The following is a description of a gene set: A protein complex which is capable of catalytic activity. Human Gene Set: GOCC_CATALYTIC_COMPLEX species: Homo sapiens, and this is the list of marker genes: ZNHIT1, POP4, SUCLG2, COX8A, POLR1H, RAMAC, SRRM1, BRPF3 (bromodomain and PHD finger containing 3), PHF21A, NDUFC2, CDK1, TCEA1, IER5, SMURF2, PPP2R3B, KLHL30, PPP4C (NCBI Gene Id 5531), KANSL1L, POLR3A, SPSB1, FARSB, PPP1R3C (NCBI Gene Id 5507), PSMD11, MCCC1, PTPA, IRS1, UGT3A2, ERCC6, TRMT61A, PPP2R5C, PSMB1, DUOX2, BECN1, CCNB1, HSPB1, KLHL21, IGF1R, MT-ND5, FBXO39, ACACB, DLST, FBXO17, SETD1B, INO80, LDHAL6B, WDTC1, MTARC1, UXS1, SUPT3H, HNRNPU, SPSB3, MT-CO2, MARCHF6, ACTL6A, SETD1A, KRTCAP2, ATP6V0E2, THBD, SEL1L, KANSL2, COX7C, IMMP2L, HDAC1, DCUN1D5, CCDC103, RANBP10, GNG4, NCF1C, PPP1R3G, KGD4, EXT1, RBM15B, SMARCA2, PRAMEF20 (NCBI Gene Id 645425), SIAH1, TAF2, MT-CYB, RSF1, ELOC, DNAH17, POLR2M, BABAM2, HNRNPAB, CAMK1G, KLHL23, BCL7B, RAD51 (NCBI Gene Id 5888), PDK1, RAD23A, ATP6V0C, FBXO25, MTA3, GSK3B, MKLN1, ELOVL6 (ELOVL fatty acid elongase 6), YPEL5, ITPR1, CUL5, RNF144B, MAD2L2, BECN2, KEAP1, PPP2R5A, PPP4R3B, ANAPC4, NDUFA4L2, RALY, ATP6V1C1, DYDC1, SPTSSA, IFIT5, DNAL1 (NCBI Gene Id 83544), GMPR2, PFKFB1, PRPF8, PCMTD1, KLHL22, FBXL6, EZH1, PSMF1, NDUFA2, PIGC, CDK9, WRAP53, PIGT, ALYREF, RBM47, STING1, DYNLL2 (NCBI Gene Id 140735), CUL4A, TBC1D5, ZBTB7A, TAF11L9, HNRNPA3, BRD8, DYNLT5, TFPT, GNAI3, DNTTIP1, ZSWIM6, DNAH2, MED31, ZZZ3, FBXO11, IKBKB, SYF2, ANP32E, LAGE3, AMT, DCAF8L1, LDHC, HNRNPA2B1, HRAS, EXOSC9, FANCI, UQCRQ, UBQLN1, MIDEAS, DYNLL1, STK11, ZSWIM8, CRADD, PSMB7, PPP2CB, PPP2R5B, FBXL2, SUCLG1, RBM8A, DHX8, ERCC8, ZYG11B, PDCD6, PRKCSH, DEPDC5, TSN, SF3B3, PPIL3, SOCS2, KBTBD2, CCNA1, MSL3, TFIP11, EME1, UBE2E1, GNG7, PRAMEF1, DDX21, PDP1, ULK1, GUCY1A2, CDK11A, GMPPA, ACTG1, ATP5F1D, CDK5R1, AQR, NDUFV2, METTL1, POP1, KLHL6, PRAMEF26, GTF2H5, GNB3, BRPF1 (NCBI Gene Id 7862), GNAZ, CTR9, DCAF12L1, CDC26, DCAF8, DBF4, HDAC6, SMARCC2, ATP6V1B1, NDUFB11, PRPS1L1, PARD3, BCAS2, NDUFA13, PPIL2, SNRPG, DGCR8, GATAD2B, NUS1, CCNK, METTL4, DNAH11, CDK6, ANAPC15, FBXW4, FBXO2, PRKAG1, HDAC4, DNAJB2, TAF11L6, EXOSC8, SPG7, CAPNS2, HCFC2, TBK1, PRDM4, DCAF1, ELP1, PAN3, PNPT1, NDUFA1, PIGY, RBBP7, INO80D, ACVR1, PIGA, SUZ12, DCAF15, DECR1, AXIN1, KMT2C, DLD, APPBP2, ATP5F1EP2 (NCBI Gene Id 432369), DCAF11, SNRPB, TAF11L10, PRAMEF11, POLR2J2, DNMT3L, GNAI1, KLHL40, PPP4R2, PPP1R3B, JMJD1C, MIB2, STUB1, CYC1, PYCARD, FBXL16, EED, PLAU, CCNT2, ASCC1, P3H3, MCRS1, AGO4, TAF11, PIGH, MED7, POLA2, QPRT, STT3B, GNA11, DCAF10, KBTBD12 (NCBI Gene Id 166348), UTY, KLHL10, TAF13, MED8, C2orf49, DISC1, ABAT, GNL3L, ACTR6, STRADB (NCBI Gene Id 66009), SAP30, DCAF4, UQCRFS1P1, CCNJ, PARD6A (par-6 family cell polarity regulator alpha), DYNC1I2, PRKDC, EXOSC4, TADA3, TOP3A, GNG5, AMN1, TSEN54, NOX4, TRAF2, RMI2, LSM2 (NCBI Gene Id 57819), DNAH9, RAC1, PPP2R2B, GTF2H2C, KMT2B, LYRM4, RNF217, MRGBP, KANSL1, VCP (valosin containing protein), DKC1, ERCC2, CCNY, GNG13, NAA11, ECPAS, ATP5MG, POLR1A, ZYG11A, SPAAR, MT-ATP8, PPIL1, PRKAG2, MED21, GNG8, RPP25L, PFKL, LIG3, CDK12, RAC2 (Rac family small GTPase 2), WDR5B (WD repeat domain 5B), PSMD13, CUL9, NAA25, PRIM2, ATP6V1B2, PPP4R4, ARID1A, UQCRHL, RABGGTB, PRAMEF12, ATP5F1B, COQ5, UBE2B, ATG16L2, PDHX, SDHC, PSMD2, PSMD6, NSMCE2, DIS3, APOBEC3F, ATP6V0A1, DAPK1, RFC1, PPP2R3A, ATP5PO, MYBBP1A, ASB4, KLHL28, UBE2L3, APC, ATP6V1H, KARS1, ASB1, METTL14, TAF10, PPIE, DCAF5, TAF3, SETD5, SNRPF, TMEM258, DPM3, NDUFA12, CALM3, GTF2F1 (NCBI Gene Id 2962), DCAF8L2, NCF4, TAF12, DDOST, NDUFC1, TRIM37, HEXA, ACTR5, UBE2J1, CDK8, KLHL3, NCF1, DCAF12L2, ATAD5, AMFR, NEU2, CYB5R3, CTU1, SDHA, BICRAL, ATP5MF, CHD3, POLR3C, DNAH14, VPS72, BRAP, NRIP1, NDUFB1, RRAGC, GNA12, NCF2, COQ4, CCNF, NDUFB4, ZNF217, A1CF, MED13, CCNC, TAF7L, RPP14, POLR2J (NCBI Gene Id 5439), POTEJ, MED30 (NCBI Gene Id 90390), PHKG2, MT-ND4, CCNP, EEF1E1, FBXO31, NAA38, CYB5B, TREX1, TAF11L7, POLR3E, KLHL42, PRKACA, CDC5L, PSME2, KLHL7, IDH3B, CSNK2A1, GAN, ING1, ATP6V0D2, DYNLRB1, GNG5B, MT-ND4L, GNG2, PRAMEF27, FBXL4, PIK3CB, OSTC, FBXO42, BUD31, PIK3R4, ATG12, GTF2E2, SRRM2, DNAH12, ASB2, COQ3 (NCBI Gene Id 96592), LUZP1, SMG5, TRMT11, GTF2H3 (general transcription factor IIH subunit 3), PCGF6, DYNC1H1, TANK, DPF2, SDHD, SAP18, FBXO3, FBXL13, RRM1, ATP5MK, PRKX, HDAC8, CBLL1, GTF2B, CHM, KLHL15, P4HB, TMEM199, RRAGA, CWC22, ATXN7, ENO2, DNAH8, RIOK1, AIMP1, PDPR, CCNI, DHTKD1, AGO1, KDM3B, GCSH, NOXO1, PRAMEF4, PCGF2, GATB (NCBI Gene Id 5188), ATG3, SAMD7, SNX4, PSEN1, FEM1B, TERC, DTL, C1D, TBPL1, JADE1, PSMD3, PSMC4, APOBEC1, KLHL12, REV3L, MLEC (NCBI Gene Id 9761), PARD6G, PHKG1, CASC3, DYNLT4, SMG7, RANBP9, ABHD11, PHF12, PSMD4, TRAF7 (TNF receptor associated factor 7), ODAD1, FEM1A, MBD3, MTCO2P12, SNW1, KHSRP, POLR2L, SUDS3, ATP5PB, RBCK1, PSMD14, WDR5, MAVS, EP400, POLR3G, YEATS2, PPP2R1A, MORF4L1, CAT, PSMD9, POLR3D, XRCC6, FBXL15, DYNC1LI2, MMS19, DIS3L, MECOM, SAP130, GANAB, ING2, HCFC1, MAX, GNAI2, PDSS2, SAE1, DCAF12, EXOSC1, SS18, CHD8, CUL4B, COLEC10, RBM15, NDUFS4, TET1, POTEE (POTE ankyrin domain family member E), KLHDC10, C15orf48, GTF2E1, POMT1, RNF11, ARID4A, SOCS7, GSK3A, MYZAP, IARS1, PAAF1, PSMB2, TMEM183A, DCTN4, TAF7, POLR2F, DPH2, ATG101, PRAMEF33, FBXO9, UBE2V2, PRAMEF13, BICRA, KLHL41, POLR2A, FARSA, PRPF31, SEM1, SMARCD2, HERPUD1, KAT6A, GNB4, DCAF4L2, NDUFB2, ZFAND2B, JARID2, RBBP5, CDC27, KLHL17, CHD5, ING3, EXOSC3, RNF19B, CAPN1, ORMDL2, GNPTG, RPAP1, CAPN2 (calpain 2), RNASEH2B, PRKACG, PPP1R15B, ZFP36, FBXO44, PCGF5, NAA15, CDK14, PRAMEF19, KLHL5, PSMB8, CCNO (NCBI Gene Id 9998), PAXIP1, POLR3B, PPP2R2C, DPM1, PIGK, UBE2J2, KCTD2, ORMDL1, PRMT5 (protein arginine methyltransferase 5), PSEN2, HADHB, ATP6V0E1, ATG14, PHC1, ILVBL, ATG13, PRKY, COX6B1, U2AF1, PRAMEF2, CECR2, DNAI4 (dynein axonemal intermediate chain 4), SPCS3, HSD17B10, ACTL6B (NCBI Gene Id 51412), GPIHBP1, MCCC2, LSM3, TRMT112, SPTLC3, RMI1, INSR, PPP3R2, SUPT20HL2, CCNG2, TAF11L12, FANCD2 (NCBI Gene Id 2177), UQCRB, SPSB2, PFKP, EXOSC5, CDK19, RBX1, EIF4A3, COX5B, DNAH10, ORMDL3, RRAGB, MTREX (NCBI Gene Id 23517), FBXO32, NOXA1, ISCU, CYBB, POLR3H, HTRA2, ANAPC5, ATP6V1F, NAA16, FBXW5, ATP23, COX5A (cytochrome c oxidase subunit 5A), ERH, DAD1, HEXB, CDK13, HR, PSMD1, NDUFC2-KCTD14 (NCBI Gene Id 100532726), P3H4 (prolyl 3-hydroxylase family member 4 (inactive)), CHRAC1, TAF5, ASCC2, WDR38, DCAF4L1, KLHL35, SF3A1, LDHA, PRAME, TSNAX, SEC11A, PPP2R5E, PRKAR1A, PNN, UBE2A, SGF29, RNF168, ANKIB1, CXXC1, KDM6B, SPOPL, CDKN2D, SNRPD2, UVRAG, RNF14, PSG9, POLR2D, SMG6, RNASEK, NOX1, SIN3B, PPP1R3D, PPP1CA, GCLM, NDUFB9, MAPKAP1, AKAP5, FBXO4, AFG3L2 (NCBI Gene Id 573970), POLR1D, PPP3CA, DHX9, CCIN, BCL7C, TAF11L2, PPP3CC, PCCB, COX6A1, RPP30, QTRT2, PAFAH1B1, KLHL9, SF3A2, MT-ND6, CFLAR, PRKAG3, LSM11, GUCY1A1, NCOA6, GRHPR, WDFY3, PRKCZ, INO80B, ZDHHC9, NAA30, BCL11B, DNMT3A, DYNLT1, BRCA2, FBXO45, BCKDK, DNAH7, OST4, TADA2A, NAA35 (N-alpha-acetyltransferase 35, NatC auxiliary subunit), BPTF, GTF2H2, PIDD1, NDUFAB1, LARS1, SART1, PHF20 (PHD finger protein 20), SUMO4, KDM3A, RAC3, SUPV3L1, PHF10, HDAC10, DHX35, LMO7 (LIM domain 7), ERN1, CACYBP, ATP5MGL, SIN3A, CDC40, NAA20, PPP3CB, RAD23B, CDK10, HADHA, SPSB4, NSMCE3, DUOX1, NDUFB6, PHKA2 (phosphorylase kinase regulatory subunit alpha 2), CHD4, HDAC3, BRMS1, PRAMEF14, RPTOR, FBXW7, EXT2, RTCB, DDX23, JADE3, PRKAA2, RUVBL1, CRNKL1, PRAMEF6, NDUFV1, PRKAR2A, TAF11L11, ATM, TUSC3 (NCBI Gene Id 7991), ZNFX1 (NCBI Gene Id 57169), DDX41, RCOR2, FRG1, CREBBP, DROSHA, LIG4, KLHL38, SS18L1, MSL2, EZH2, CCNB3, CBX2, NSMCE1, PMPCB, POLR2G, FBXO27, KMT2E, ACTR8, GCLC, PSMA7, INO80E, MAT2A, TAF11L13, CBX7, PSMB11, CCNL1, THUMPD3, TAF9, DMAP1, DYNC1LI1, FBXL17, RNF8, DDX1, SMC6, DICER1, RBBP4, TICAM1, EPC2, CAMK2A, CFH, BAZ1B, GNG12, TOP2A, HNRNPA1L2, PPP2R2A, TSEN34, TAF5L, PSMD10, ELP5, DNAI3, CASP8, SUCLA2, PSMB10, PPP2CA, PHF1, ATP5F1C, ACTB, OGT, FBXO24, UBE2N, COX6C, RPP38, HNRNPC, NDUFB10, ACTL8, BCOR, USP22, NDUFA5, ATP5MC1, DCAF7, SESN2, ELP4, MAP3K7, ZER1, TRRAP, PRAMEF18, PSME3, TPR, FBXO10 (F-box protein 10), IVNS1ABP, UQCRH, DPF3, VIRMA, F13A1, DAW1, SINHCAF, PBRM1, SMC5, ATP6V1C2, OS9, NOP10, DBT, BLM, COX6B2, RIPK1, RUVBL2, CCNG1, NDUFA6, UQCR10, USP33, SPCS2, TEP1, ATP5MJ, PSMA8, NSMCE4A, GTF2A1L, CCNL2, GNG10 (NCBI Gene Id 2790), DYNC2I2, AIMP2, PLOD1, ANAPC7, CDK5 (NCBI Gene Id 1020), PSMA2, CTDNEP1, ANAPC1, ATP5F1E, DCUN1D3, FNTA, FAM8A1, RARS1, GOLGA7, SENP3, SEC11C, MSL1, FZR1, EXOSC6, NDUFAF2, POLD3, KBTBD3, MT-CO1 (NCBI Gene Id 4512), EPRS1, UQCRC2, NRBF2, GLDC, FBXO48, POLG, KANSL3, MAGOHB, PDHB, RTF1, ANAPC11, GATC, MED1, ATP6V0A4, POLA1, RPP40, PPWD1, TBL1Y, ATP6V1D, GTF2A2, FEM1C, DNAH5, PRAMEF25 (NCBI Gene Id 441873), HNRNPK, MPHOSPH6, FBXW11, TAF6L, POLD4, PPP2R5D, KCTD5 (NCBI Gene Id 91152), PIK3R2, NCOR1, RB1, PSMB4, ATG16L1, HDAC5, INSRR, APC2, ARIH1, RB1CC1, PPP1R3A (protein phosphatase 1 regulatory subunit 3A), BCKDHB, AKAP14, SF3B1, SIRT1, GPR37, CTNNB1, F3, WDR26, SEC11B, PRKAB2, SPTLC1 (serine palmitoyltransferase long chain base subunit 1), RPN1, KCTD17, ZSWIM4, N6AMT1, ATP6V1E1, THG1L, EID3, PPP1R15A, DCTN1, PRKCI, FNTB, USP14, RNF144A, CAND1, PSMC3, EXOSC10, PRKRA, TERT, NDUFS8, POLR3K, PSMC6, PTGES3, SUPT20H, NUDCD3, CAMK2B, PRKACB, ERCC3, SMARCC1, EME2, CCNQ, USP47, CDK11B, PSME4, BARD1 (NCBI Gene Id 580), UGT3A1, PPP1R3E, GMPPB (NCBI Gene Id 29925), CHML, F7, GNA14, KAT2B, NDUFV3, PSMB6, ATP6V0A2, CCND3, POLE2, DNALI1, INO80C, MBTD1, CCND1, PIGM, ASB11, COX7A2, GOLGA7B, ALG14, FCN3, NHP2 (NHP2 ribonucleoprotein), TOX4, C9orf72, ANAPC16, PCGF1, PAXX, FXN, CARHSP1, DBF4B, SUPT7L, CUL3, PFKM, PHF20L1, DNAI7, POLE, CRBN, CKS2, PSMD8, TNFAIP1, PHF19, AGL, KAT7, COQ7, ATP6V0B, KLHL2, NOX5 (NCBI Gene Id 79400), COMMD1, KAT5, UBQLN4, CDC16, PPP1R12A, MEN1, SMARCA4, TADA2B, RCOR1 (REST corepressor 1), ACVR2A, IKBKG, PEX2, ACD, HNRNPR, CCNB2, CWC27, DPH1, NKD1, POLG2, PARD6B, TAF11L14, TBL1XR1, PAN2 (NCBI Gene Id 9924), CCNE2, TXNL1, CBX5, MTOR, CHUK, EPC1, RTRAF, PRAMEF10, RNF19A, NAA50, PIK3R3, CDK3, PRPF6, NAA10, CBX6, COX6A2, FUT6, PLAUR, KLHL4, FBXO6, HPSE, LPL (lipoprotein lipase), CCDC115, SYVN1 (synoviolin 1), FBXL19, POP7, TSEN2, SNRPN, DHDDS, KLHDC1, PYDC1, DNAL4, MTA2, ACVR1B, BAZ2A, APH1A, PAFAH1B3, PLRG1, KLHL8 (kelch like family member 8), SOS1, NEDD4, ALG13, MT-CO3 (NCBI Gene Id 4514), PALB2, CASP9, GMPR, RRAGD, HDAC9, DMAC2, ATXN7L3, PHKB, SNRNP40, KLHL18, ATP5ME, SHOC2 (NCBI Gene Id 8036), MED11, OTULIN, GNA13, TADA1, PABPC1, TRPC4AP, PSMD5, DPF1, SNRPD1, NDUFA7, POLD1, DCLRE1C, SATB2, PSMA1, SPCS1, FBXL14, FBXO21, DNAH1, ELP6, SMCR8, BUB1B, TUFT1 (tuftelin 1), CDK4, UQCR11, WDR4, MAGOH, ATP5F1A, RICTOR (NCBI Gene Id 253260), POLR2E, PIGV, ARMC8, SMARCD3, DYDC2, PCGF3, QARS1, NDUFB8, NDUFA11, KDM1A (NCBI Gene Id 23028), BAZ1A, DDX5, NOX3, RNASEH2A, RABGGTA, COX7B2, PGGT1B, PAFAH1B2, ANAPC10 (NCBI Gene Id 25866), SNRNP200, SRSF1, MCM3 (minichromosome maintenance complex component 3), GPATCH1, CAPNS1, CDK2, POLE4, COX4I2, TRMT61B, BCS1L, NDUFA8, UBE3D, MOCS2, ARIH2, POTEKP, ZCCHC8, F13B, XRCC4, KLHDC2, DNAI1 (NCBI Gene Id 3393), PSMC2, NFS1, ADRM1, PEF1, PMPCA, RBM22, ANAPC2, BCL7A, CDKN1B, ATF2, DYNC2I1, CSNK2B, NDUFA4, ASB12, PSMD7, PIK3C3, CAMK2D, DPM2, BRCA1, MAT2B, HINT1, CYREN, PCNA (proliferating cell nuclear antigen), MTA1, NDUFA9, KLHL20, GTF2H2C_2, TRERF1, DNAH6, GNAT1, ATP6V1A, CDK2AP1, ARID2, HNRNPH1, ZFAND2A, UBE4B, MED12, MLST8, RNF31, LDHB, COQ9, TAF6, DR1, NCSTN, RAG1, DYRK2, AEBP2, GNAS, GATAD2A, PRKAB1, BOD1L1, BTRC, TBL1X, CASP2, NAT10, CUL2, DYNLRB2, GON7, GNAT3, POLR3F, IDH3G, ACVR1C, GID4 (NCBI Gene Id 79018), RNF2, UBE2S, GNB1, COX8C, NEK10 (NIMA related kinase 10), JADE2, HNRNPA1, SMARCB1, COX7A2P2 (NCBI Gene Id 345363), PAF1, TAF11L3, YY1AP1, POLR2C, NDUFS1, SLU7, GNG14, PRAMEF7, POLR2I, SAP30L (SAP30 like), CDK7 (NCBI Gene Id 116024), PSMD12, RING1, PHKA1, COP1, TBKBP1 (NCBI Gene Id 9755), DET1, UBE2I, CBX4, UBE2U, UBR2, PSMC1, NDUFS5, ZBTB8OS, IPP, NDUFS7, MAP3K5, GNB2, PIK3R1, XRCC5, FBXO46, TRMT6, FAP, RANBP2, PRICKLE1, CCNH, HNRNPF, COQ6, NDUFS6, DPY30, C17orf49, DYNC2LI1, MEGF8, BRD1, PPP2R1B, PSMB3, DYNC2H1, PPP2R2D, KBTBD7 (NCBI Gene Id 84078), CDKN1A (NCBI Gene Id 1026), ATP6V0D1, ANKRD9, DEK, PSMA5, HSD17B12, KLHL24, NCF1B, WTAP, MORF4L2, CCNE1, NCR1 (NCBI Gene Id 9437), LZTR1, GTF2F2, FAM98C, ELP2 (NCBI Gene Id 55250), TRIM40, CCNJL (NCBI Gene Id 79616), CCNT1, SLX4, IKBKE (NCBI Gene Id 9641), MT-ND3, TAF9B, PHC2, MED6, RERE, GNAT2, DCUN1D1, ATP6V1G2, MEAF6, WWP2, PRAMEF17, DNA2, FBXO38, TAF11L8, FBXL21P, SAMD11, UBE4A, COX10, DDA1, WDR77, STRADA, RPP21 (ribonuclease P/MRP subunit p21), DCAF6, CDC20B, TOPORS, GLMN, ZC3H13, HDAC7, TAF4B (NCBI Gene Id 6875), FADD, PIK3R6, TBP (NCBI Gene Id 6908), PPP1R3F, APH1B, CDC20, KLHL25, ATG5, MYO1C, SF3A3, NDUFB7, GNG3, KAT14, PPP3R1, PRP4K, CAMK2G, TRAF3, TAF1, PRAMEF22, ERC1, FBXL3, TAF11L4, PRIMPOL, FBH1, BCCIP, TPRKB, DCAF17, YJU2, RCHY1, FAM98A (NCBI Gene Id 25940), MGA, CSNK1A1, PRAMEF9, RMND5A (required for meiotic nuclear division 5 homolog A), HDAC11, CACTIN, RANGAP1, POLR1C, SNRPE, PHC3, RBM44, UBR3, PDHA1, PKLR, IMMP1L, ATP6AP2 (NCBI Gene Id 95880), ENY2, KLHL13, CALM2, TCIRG1, PRPS1, WDR83, GNAO1 (G protein subunit alpha o1), HNRNPA1L3, KCTD10, FBXL20, EXOSC7, MT-ATP6, SNRPA1, RNF40, PIGU (phosphatidylinositol glycan anchor biosynthesis class U), CDK16, PIK3R5, MED17, CTNNBIP1, BCL11A, ARID4B (AT-rich interaction domain 4B), ATP5MC3 (NCBI Gene Id 518), NDUFA3, PRIM1 (DNA primase subunit 1), POLR2B, HSD17B8, MNAT1, OGDHL, POLR1E, ATP6AP1, WWP1, MGRN1, UCHL5, MED27, UBE3C, CAB39L, ESS2, DDB2, ELP3, MAT1A, GTPBP3, KAT8, QTRT1, CDK5R2, PRAMEF5, PPP4R1, MRAS, NDUFA10, CNEP1R1, AZI2, RPN2, COX7B, DHX38, SMARCA1, ASCC3, EPOP, CCNA2, EP300, ASB9, PPP4R3A, DMAC2L, PRAMEF8, CKS1B, MTO1, ENO3, BMI1, PPP4R3C, CFDP1 (craniofacial development protein 1), WDR74, PRKN, NCCRP1, SMARCE1, UBAC1, TP53RK, RRM2B, P4HA1, WDR18, VPS4A, SUPT20HL1, POLRMT, DLAT, VAC14, FBXW8, GNA15, DNAH3, ENO4, XAB2, HNRNPM, DYNLT2, CCND2, TEX10, PDHA2, PIGS, AKAP4, UQCRFS1, CNPPD1, TAF1L, DACT1, FCN2, GTPBP1, MT-ND1, SPTSSB, PIAS4 (protein inhibitor of activated STAT 4), CLPP (caseinolytic mitochondrial matrix peptidase proteolytic subunit), ATP5PF, NDUFB3 (NADH:ubiquinone oxidoreductase subunit B3), DNAI2, PSMA6, POLD2, RNMT, POLR2J3, APOBEC3G, UBE2C, SCLY, DCUN1D2, SUGT1, KMT2A, RPPH1, LEO1, GNG11, CSNK2A3, ARID1B, MAEA, KLHDC3, RNF7, BOD1, DRC1, NME8, PAGR1, GNAL, CFAP70, MBIP, NDUFS2, KMT2D, LSM7, CCNI2, DYNC1I1, PPP1R9B, NHEJ1, CASP10, KAT2A, AXIN2, ATP5MC2, TENT2, MAGT1, PSMA4, PIGQ, COX4I1 (cytochrome c oxidase subunit 4I1), CDC23, CBX8, GTF2H1, FBXO8, PDSS1, PIK3CA, ASH2L, GID8, RFC4 (NCBI Gene Id 5984), TMED10, ENO1, SMARCA5, LAS1L, ATP5PD, ZNF335, TP53BP1, PRKAR2B, PELP1, SHARPIN, BRD9, CRCP, SKIC8, ANAPC13, DCUN1D4, METTL3, CBR4, PIK3CD, WDR93, SPOP, AMBRA1, OGDH, CDC73, GBA3, GNGT1, AGO3, DYNLT3, PRMT1, BRD7, CUL1, GNAQ, RCOR3, GNGT2 (NCBI Gene Id 2793), DNMT3B, UBR1, PRKAA1, EXOSC2, MT-ND2, MSL3B, KLHL1, FBXL12, SLF1, PDK2, KAT6B, FAM98B, RBMX, PRKAR1B, CWC15, MARS1, QRSL1, GTF2A1, RMND5B (NCBI Gene Id 64777), TGFBR1, NDUFS3, CLNS1A, RPP25, OSGEP, CSNK2A2, KBTBD6, POTEF, GNB5, PPP1R10, POP5, EFTUD2, GTF2H4, POLR1B, MBD2 (methyl-CpG binding domain protein 2), GAR1, TMEM183BP, DDB1, FBXL7, COX7A2L, SF3B5 (splicing factor 3b subunit 5), RNF20 (ring finger protein 20), AGO2, CWC25, SDHB, PRPF19, TAF4, SNRPB2, CLP1, PSMB9, KLHL11, PIGP, UBXN8, ATP6V1G3, VPS4B, ISY1, COLEC11, POLE3, FBXL5, PSMB5, KLHL29, BCKDHA, DCTN2, GPAA1, RRM2, PSME1, YEATS4, ENC1, ACTBL2, TARBP2, TGFBR2, SMARCD1, SF3B2, E2F6, DNHD1, ZSWIM5, TAF8, BRMS1L, HMGXB4, PRORP, DCAF16, THUMPD2, UBE3A (ubiquitin protein ligase E3A), DCAF13, ARMC5, CALM1, ELOB, POLR2K, BRCC3, CYBA, SNRPGP15, WDR82, SKP1, FBXO15, NFRKB, PCCA, ZFC3H1, PRAMEF15, ING4, TRIM21, POLR3GL, FBXO7, CUL7, CDK2AP2, NVL, SNRPD3, KDM6A, YY1, DYNLT2B, PPCDC, SLF2, MBL2, KCTD13, LRRC75A, NDUFB5, RNASEH2C, IDE, FCN1, KBTBD8, COX15, UQCRC1, STT3A (STT3 oligosaccharyltransferase complex catalytic subunit A), MTF2, MUS81 (NCBI Gene Id 80198), RAD18, HDAC2, TRMT10C, PIK3CG, ABTB1, CLPX, NCK1, ZNF541, UBE2V1, PPP1CC, POLR1F, POTEI, ACVR2B, CAB39, SRCAP, UBA2, POLR1G, PPP1CB, PSMC5, PSMA3, GUCY1B1, PSENEN, POLR2H, MED10, SPTLC2, ING5, DARS1, SYNCRIP, CCDC65, COX7A1, ATP6V1G1, SKP2, IDH3A